Given this list of marker genes Xylt2 (NCBI Gene Id 217119), Hyal4, Chst13, Glb1l, Hs3st2, Csgalnact1, B3gat1, Sdc3, Acan, Hmmr, B4galt6, B3gat3, Ext1, Hs3st4, Slc26a11, Bgn, Hs6st2, Slc9a1, Hexa, Chst5, B3gnt3, Omd, Hexb, Glb1l2, Chst12, Slc35b2, Stab2, Chst14, Gpc3, Slc26a1, Sgsh, Ndst2, Hs3st3b1, Hs6st3, Chst2, Xylt1, Chst15, Lum, B3galt6, Naglu (NCBI Gene Id 27419), Hyal2, Dsel, Gpc2, Slc26a2, Dse, Galns, Hyal5, St3gal2, Chst9, Slc35d2, Ndst3, Chsy3, Kera, Dcn, Chsy1, St3gal4 (ST3 beta-galactoside alpha-2,3-sialyltransferase 4), B3gat2, Glb1l3, Has1, B4galt7, Hs6st1, Cspg5, Hpse2, Ust, Sdc1, Csgalnact2, Hyal1, St3gal3, Ids, here is a description of the gene set: This event has been computationally inferred from an event that has been demonstrated in another species.<p>The inference is based on the homology mapping from PANTHER. Briefly, reactions for which all involved PhysicalEntities (in input, output and catalyst) have a mapped orthologue/paralogue (for complexes at least 75% of components must have a mapping) are inferred to the other species. species: Mus musculus part of: Metabolism of carbohydrates and carbohydrate derivatives Reactome Pathway: Glycosaminoglycan metabolism electronically inferred by orthology from the curated human pathway